The following is a description of a gene set: studied in species Homo sapiens The addition of an acetyl group to a non-terminal lysine residue in a protein. Human Gene Set: GOBP_INTERNAL_PEPTIDYL_LYSINE_ACETYLATION, and this is the list of marker genes: EP300, NAT8, KAT7, KAT2A, ATAT1, NAT8B, BAG6, KAT2B